The following is a description of a gene set: The process in which the anatomical structures of a limb joint are generated and organized. A limb joint is a flexible region that separates the rigid sections of a limb to allow movement in a controlled manner. Human Gene Set: GOBP_LIMB_JOINT_MORPHOGENESIS species: Homo sapiens, and this is the list of marker genes: ERRFI1 (NCBI Gene Id 54206), COL3A1, EXT1, OSR1, COL6A1, CTNNB1, OSR2